The following is a description of a gene set: from publication Chen Y, Wang X (PMID 31504780) Human Gene Set: MIR6890_5P studied in species Homo sapiens Genes predicted to be targets of miRBase v22 microRNA hsa-miR-6890-5p in miRDB v6.0 with MirTarget v4 prediction scores > 80 (high confidence targets)., and this is the list of marker genes: ZNF189, LPCAT2, POC1B, ZNF37A, NONO, C22orf39, DYNC1I2, NCAPH, SLC39A8, NDRG4, RC3H1, WDFY3, NOVA1, TRAPPC3, VIPR2, ACBD7, NALF2, BBS9, SLC22A4 (solute carrier family 22 member 4, NCBI Gene Id 6583), HELZ